Given this list of marker genes TULP1, SPATA7, PCARE, ROM1, BBS4, TUB, ZDHHC3, here is a description of the gene set: Human Gene Set: GOBP_PROTEIN_LOCALIZATION_TO_PHOTORECEPTOR_OUTER_SEGMENT A process in which a protein is transported to, or maintained in, a location within a photoreceptor outer segment. species: Homo sapiens